The following is a description of a gene set: species: Homo sapiens Human Gene Set: GOBP_NEGATIVE_REGULATION_OF_MITOCHONDRIAL_FISSION Any process that decreases the rate, frequency or extent of mitochondrial fission. Mitochondrial fission is the division of a mitochondrion within a cell to form two or more separate mitochondrial compartments., and this is the list of marker genes: MAPT, PINK1, C11orf65, PPARG (NCBI Gene Id 5468), PRKN